The following is a description of a gene set: A ribonucleoprotein complex that contains small nuclear RNA U4, a heptameric ring of Sm proteins, as well as several proteins that are unique to the U4 snRNP, most of which remain associated with the U4 snRNA both while the U4 snRNP is free or assembled into the U4/U6 snRNP or into a series of spliceosomal complexes. species: Mus musculus Mouse Gene Set: GOCC_U4_SNRNP, and this is the list of marker genes: Snrpd1, Snrpf, Snrpb, Snrpd2, Prpf31, Snrpd3, Snrpert, Snrpg, Snrpe, Snrpn, Ddx39b